Given this list of marker genes Stk4, Stk3, Gcm1, Snai1, Elf5, here is a description of the gene set: Mouse Gene Set: GOBP_REGULATION_OF_CELL_DIFFERENTIATION_INVOLVED_IN_EMBRYONIC_PLACENTA_DEVELOPMENT Any process that modulates the rate, frequency or extent of cell differentiation that contributes to the progression of the placenta over time, from its initial condition to its mature state. studied in species Mus musculus